Given this list of marker genes CEP19, BBS4, GSK3B, CCDC68, HOOK3, BICD2, MAP1S, CCDC120, DCTN1 (NCBI Gene Id 82109), NINL, BICD1, NIN, KIF3A, PCM1, here is a description of the gene set: species: Homo sapiens Human Gene Set: GOBP_MICROTUBULE_ANCHORING_AT_MICROTUBULE_ORGANIZING_CENTER Any process in which a microtubule is maintained in a specific location in a cell by attachment to a microtubule organizing center.